The following is a description of a gene set: studied in species Mus musculus Mouse Gene Set: MIR_6391 Genes predicted to be targets of miRBase v22 microRNA mmu_miR_6391 in miRDB v6.0 with MirTarget v4 prediction scores > 80 (high confidence targets). from publication Chen Y, Wang X (PMID 31504780), and this is the list of marker genes: Zfp661, Tead4, Tns4, Mindy2, Usp13, Kcna6, Zfp442, Tns3, Kbtbd2, B4galt2, Tmbim1, Tlk2, Cdc42se1, Rab9, Cep85, Klhl20, Syt14, Cyp2b9, Ereg, Ywhaz (tyrosine 3-monooxygenase/tryptophan 5-monooxygenase activation protein, zeta polypeptide), Mycbp2, Galnt7, Cep97, Csnk1g1, Vwa5b2, Strbp, Tmem94, Pigr, Pabir2, Cacna1d, Mavs, Eif4ebp1, Stra6, Ece2, Stk3 (NCBI Gene Id 80435), Grb10, Csgalnact2, Dlgap4, Fcho2, Kcna2, Smg1, Lrrc7, Smarcd2, Gnaq, Klrg1, H1f0, Ppp1r2, Rhbdl3, Frem2, Slc44a2, Ccdc177, Unc5b, Hycc2, Tbc1d4, Tlr3, Fignl1, Plxna4, Kpna3, Nup160, Marchf6, Lpp, Mtcl2, Gstk1, Metap1, Chrnb2, Epha6, E2f6 (NCBI Gene Id 50496), Tspoap1, Hepacam, N4bp1, Dkk2, Atp8a1, Oga, Trib2, Poglut1, Hdhd5, Gbe1, Trak1, Hook1, Satb2, Gnptab, Gjc1, Mvd, 5031439G07Rik, Fabp3, Tmed7, Scd1, Stk40, Ark2c (NCBI Gene Id 72870), Wtip, Serf2, Lsm11, Mapk14, Rfx2, Egln1, Mccc1, Txlna, Entpd7, Ptpru, Lmbr1l, Elovl1, Vps13d, Mid1, St6galnac2, Tacc1, Nedd4l, Daam1, Ttn, Trappc12, Ly6e, Mthfd2l, Fam107a, Nhsl3, Vdr, Gpr119, Caprin2, Zranb2, Zfp9, Myc, Ahr, Acss1, Fdx1, Septin9, Acbd5, Plxnc1, Plk3, Tsga10, Gsdma, Ralgapa1, Nelfe, Srsf2, Celsr1, H2-Ob (NCBI Gene Id 15002), Fermt1, Arid3a (NCBI Gene Id 13496), Dgka, Carmil3, Zfp280b, Arpin, Fgd5, Sbno2, Pald1 (NCBI Gene Id 27355), Ergic1, Ppp1r9b, Fam83h, Morn4, Kat7, Bltp2, Iqgap2, Acads, Kdm2a, Slc4a4, Tcl1b5, Slc22a15, Zc3h11a, Cyp2b13, Gm5878, Eef1ece2, Mif4gd, Spred1, Ell, Lrp8, Tmem229a, Prune2, Sema4f, Rmnd5a, Tmem179, Mboat1, Elmod1, Cemip, Plekhf2, Scoc, H6pd, Erg, Irf6, Pfkfb2, Arhgap21, Kirrel3, Pag1, Tm9sf2, Smarcd1, Bcl2l13, Ubn2, Ctdspl, Tcf25, Stk32b, Kcnk4, Ptgr3, Cand2, Retreg1, Faxc, Tmem231, Hey1, Pacs2, Tcl1b3, Chrdl1, Mief1, Npc2, Sgk3, Pgm5, Rex1bd, Tmem170b, Ahcyl2, Serinc2